The following is a description of a gene set: studied in species Mus musculus Any process that activates or increases the frequency, rate or extent of the chemical reactions and pathways resulting in the formation of glycogen. Mouse Gene Set: GOBP_POSITIVE_REGULATION_OF_GLYCOGEN_BIOSYNTHETIC_PROCESS, and this is the list of marker genes: Ppp1ca, Igf1, Pth, Epm2aip1 (EPM2A interacting protein 1), Dyrk2, Gck, Insr, Ppp1r3g, Ppp1r3b, Irs2, Ins2, Akt2, Irs1, Igf2, Esrrb, C1qtnf2, Ppp1r3e, Ins1, Akt1, Sorbs1